Given this list of marker genes SYT11, EIF5, POLR2G, ZPR1, PPP1R15A, ANGEL1, C8orf88, EIF3C, EIF3CL, EIF3B, TRIM32, EIF4G1, LIN28A, LARP1, EIF4EBP2, OTX2, EIF3F, EIF3M, EIF2B4, RPS24, TBL2, HHEX, EIF4E, EIF2S2, DDX3X, EIF2B5, DAPL1, NCK1, FMR1, EIF4EBP1, EIF4EBP3, GLE1, POLR2D, here is a description of the gene set: Human Gene Set: GOMF_TRANSLATION_INITIATION_FACTOR_BINDING species: Homo sapiens Binding to a translation initiation factor, any polypeptide factor involved in the initiation of ribosome-mediated translation.